Given this list of marker genes ATN1, SLC9A1, ANK1, WDR1, DLG5 (discs large MAGUK scaffold protein 5), NCKAP1L, PDCD6IP, GSK3B (glycogen synthase kinase 3 beta), CRB2, LHX2, PDLIM1, WNT11, DST, NHERF1, here is a description of the gene set: The maintenance of established anisotropic intracellular organization or cell growth patterns. studied in species Homo sapiens Human Gene Set: GOBP_MAINTENANCE_OF_CELL_POLARITY